Given this list of marker genes USP30, WEE2-AS1, ZNF337-AS1, PUS10, AKR1A1, TDP2, ESYT1, SPSB4, DCTN4, NOVA1, EXOSC3, PHF12, MIR4432, TRDMT1, SCAND1, MTF2, ITGA3, RNU6-1316P, FAM13A, STK32C, FOXE3, ABI1, ZNF391, HCG27, PISD, NUP210, ZNF37A, SLC6A6, GTPBP3, LINC01900, RMND1, ACAD10, GPATCH4, CAMK1, SMARCD2, STX8, ENSG00000266313, SPPL3 (signal peptide peptidase like 3), NME1-NME2, NOC2L, CIZ1, PARD3B, LINC00431, KAT8, ZNF451, RNVU1-15, B4GALT4, ZNF566, SELENOO-AS1, ZNF721, TPRKB, RUSC2, PPIP5K2, ATG4C, ANKRD12, PLEKHG5, CBFB, GTF2IP20, LINC01596, EGLN3-AS1, PRSS22, TBC1D19, IFTAP, ADAP2, SSBP1, WNT5B, UBE4B, BCRP2, C1orf159, KPNB1, BRIP1, TRAPPC13, PGAP2, CARD19, CXCL12, MAPK10, VOPP1, SRSF7, VTRNA1-3, LINC00511, SUMO1, MRPS31, ESCO1, BCRP3, LL22NC01-81G9.3, CEP104, USP7, RPL37, PTENP1-AS, MIR1302-3 (microRNA 1302-3), GNAL, PLAC8 (placenta associated 8), ATP5F1E, TCF12, CRKL, RFFL, MFN1, IPO13, BRS3, ZNF350, TATDN3, ENPP3, ZNF84, SF3A3, EPS8L1, POU2F1, LINC02918, DSTYK, PRR13, VPS13B, TMEM242-DT, MTND5P11, TMCO5B, SREBF1, PLEKHM3, FBXO32, RAPGEF4, ADPRS, SCIRT, SMC3, PAXBP1, TACO1, TTC14-DT, CXCL2, IRAK4, ASCC3, LINC03122, PTPA, DMAP1, LINC00910, CCDC150, NDUFAF1, EGR2, ZNF775, PPP2CA, ZNF121, OPN3, NICOL1, SNAPC1, AKAP1, LYPD3, PUS7L, PRRC1, MCF2L, GALNT9-AS1, SEC22B, ARID1B, RALBP1, ZNF573, FAM181A-AS1, SLC25A10, HMGN4, PGRMC2, JPX, SYNJ1, DXO, LYPD6, MAP3K4, EWSAT1, LINC02842, C6orf62, MIR4435-2HG, EIF5A2, DPH6, SPEF2, NOVA1-DT, CRK, EPHB3, NDUFV2-AS1, HILPDA, RPL24P9, CHML, RNU6-782P, EGLN3, SRFBP1, ZNF829, ABCA11P, CSTF3, RNU6-114P, PRKCH, WDR11-DT, GPX8, SEPTIN7P13, PDXK, POLI, LRRC41, RN7SL159P, C18orf21P1, TRAPPC2, CDK5RAP1, TCEANC2, SMG8, WDR59, GADD45B, RBM17, MTCO3P12, CACNA1A, SSB, GSTCD, SLC13A3, KLHDC9, TUBAL3, KLHL12 (kelch like family member 12), ZNF227, RNF11P2, SDE2, FEM1C, PODXL, RPS4XP20, TBC1D31, CLK4, AHCTF1, RNU2-4P, PARN, GIN1, BUB1, LINC02136, FGD3, CSTF3-DT, CDC25A, STK19, LINC02513, DPH6-DT, CDC5L, ENSG00000231424, CACNA1C, DPY19L4, RNF217, ATG5, ZC3H11A, XXYLT1, ZNF892, INSR, GEMIN6, ZNF318, INTS12, HBP1, KCNJ6, RNU6-437P, PHC1, DDIT4 (NCBI Gene Id 54541), ACOT13, ZNF554, VPS13B-DT, AP1S3, ACACA, SETD4, GALNT9, PEX13, MED23, GIT1, DDX11L10, CREB5, TTC14, LINC02888, NCOA1, ZNF221, ARHGEF10L, COQ8B, KHSRP, PCLAF, SULT6B1, TRIP4, UIMC1, RXRG, AFG2A, ARMT1, GBA1, TRADD, GNG4, LINC01719, PPP2CA-DT, CELF5, RBBP9, EPCIP-AS1, CNKSR2, LYSET, FKBP1AP3, NSL1, UBTF, TUBA1B, KIAA1586, ELOVL2-AS1, CPNE8, VTRNA1-2, DIDO1, BACH1-AS1, SPACA6, LARP4, DNAAF5, ERCC6, RBM45, BRAP, CFDP1, RASSF6, CPAMD8, ZNF879, MTMR9, TRIM23, PTENP1, WDR11, LINC01535, HIVEP1, ZNF506, ZNF793-AS1, RTRAFP1, SDR39U1, ZNF846, POP4, RPL34, AURKAIP1, ZNF793, LINC02387, LINC00574, SETP17, SHLD3, USP43, CLTC, MATCAP1, MRPS31P5, MIR1587, SNAPC5, RABGAP1L, REPIN1, ENDOG, KANSL3, DNM1, USP32, ZNF233, NUDT6, TXNIP, ARIH2OS, MAML2, STIP1, SNORD3A, MINDY3, ZNF708, TTI2, HILPDA-AS1, PAK1, IGFLR1, ZNF280D, AMOTL2, STOX2, TARS2, CHID1, ZNF529, TMEM242, TMEM44-AS1, ELOVL2, ZNF76, RNU6-1051P, TSC22D4, SCAND3, CMKLR2, PFKL, ZBED6, LRCOL1, ANO8, NME1, ZNF568, LCMT1, RPL15, KPNB1-DT, RHOT1, ZC3H10, PTRHD1, SLC22A15, NUP93, CTNNB1, NKIRAS1, C17orf75, NDUFS2, MIR4512, here is a description of the gene set: Genes containing one or more binding sites for (ZNF331) in their promoter regions (TSS -1000,+100 bp) as identified by GTRD version 20.06 ChIP-seq harmonization. studied in species Homo sapiens from publication Yevshin I, Sharipov R, Kolmykov S, Kondrakhin Y, Kolpakov F (PMID 30445619) Human Gene Set: ZNF331_TARGET_GENES